The following is a description of a gene set: A circulatory system process carried out by the heart. The heart is a hollow, muscular organ, which, by contracting rhythmically, keeps up the circulation of the blood. The heart is a hollow, muscular organ, which, by contracting rhythmically, keeps up the circulation of the blood. Mouse Gene Set: GOBP_HEART_PROCESS species: Mus musculus, and this is the list of marker genes: Tac1, Kcnj5, Myl4, Pde5a, Drd2, Gjc1 (NCBI Gene Id 353069, gap junction protein, gamma 1), Zc3h12a, Sod1, Prkca, Sptbn4, Kcnj2, Fxyd1, Bin1, Flna, Sp4, Kcne5, Gch1, Tafazzin, Snta1, Rnls, Bves, Cxadr, Hbegf, Pebp1, Adora1, Trpm4, Map2k6, Oxt, Adrb2, Rgs4, Csrp3, Tmem161b, Chga, Znhit1, Scn4b, Ttn, Myh6, Tacr3, Rangrf, Hsp90aa1, Hey2 (NCBI Gene Id 30802), Adm, Irx3, Dsp, Ccn2, Cav1, Gaa, Actc1, Gata4, Myl7, Chrna7, P2rx4, Ucn, Pik3r1, Akap6, Pde4d, Adcy10, Smad7, Hopx, Ctnna3, Tmem38b, Fyn, Nedd4l, Kcnq1, Gja1, Kcnd3, Gpx1, Map2k3, Nmu, Adrb1, Avpr1a, Zfas1, Cacna1g, Hdac4, Smtn, Atp2a2, Edn2, Apela, Trex1, Cacna1h, Fgf13, Tnni3k, Slc8a1, Atp1b1, Kcne3, Kcna5, Kcnip1, Rap1gds1 (RAP1, GTP-GDP dissociation stimulator 1), Nkx2-5, Tnni3, Kcnh6, Gsk3a, Ext2, Atp5pf, Tbx18, Trpv1, Ada, Dmd, Stc1, Myl3, Tnni2, Mybpc3, Nos1, Ace, Zmpste24, Popdc2, Edn3, Pln, Nppa, Ramp3, Srebf1, Rps6ka2, Tnnc1, Slc1a1, Scn2b, Tcap, Adra1b, Chrm3, Myl2 (myosin, light polypeptide 2, regulatory, cardiac, slow), Rnf207, Myh7b, Dlg1, Rac1, Sumo1, Scn1b, Nup155 (nucleoporin 155), Rgs2, Slc4a3, Ednrb, Calm2, Mdm4, Gnai3 (G protein subunit alpha i3), Adm2, Ifng, Gnao1, Pik3ca, Hcn4, Gja5, Cdc42, Mdm2, Ptpn1, Camk2d, Kcnh2, Vegfb, Ace2, Cxcr4 (NCBI Gene Id 12767), Cacna1b, Kcnd2, Atg5, Tmem38a, Shox2, Scn5a, Nox4, Thra, Tgfb2, Isl1, Mef2a, Nos1ap, Myh7, Kcne2, Kcne4 (potassium voltage-gated channel, Isk-related subfamily, gene 4), Slc9a1, Pkp2, Casq2, Gsn, Kcnj8, Trdn, Tbx5, Cacnb2, Hrc, Sema3a, Atp1a3, Atp2a1, Chrm2, Crhr2, S100a1, Calm1, Scn10a, Dsg2 (NCBI Gene Id 52489), Ryr2, Tbx2, Smad5, Ppp1r13l, Agtr2, Tnf, Grk2, Strit1, Glrx3, Yap1, Edn1, Tnnt2, Myl1, Abcc9, Cacna1c (NCBI Gene Id 619317), Spx, Pmch, Uty, Klk1b1, Agrn, Dmpk, Irx5, Cacna1d, Cacna1e, Mtor, Ppcs, Ffar3, Tmem65, Akap9, Jup, Src, Gata6, 3425401B19Rik, Nos3, Kcnip2, Gpd1l, Srsf1, Wwtr1, Adra1d, Ext1, Gjd3, Sgcd, Adra1a, Ankrd11, Uts2, Dsc2, Npff, Sgcz, Sirt1, Scn3b, Psen2, Bmp10, Met, Thrb, Ank2, Kcne1, Mir208a, Glp1r, Th, Ednra, Atp2b4, Atp1a1, Tnni1, Epas1, Fkbp1b, Apln, Cacna2d1, Cav3, Kcnn2, Sgcg, Gnai2, Foxn4, Mc3r, Scn1a, Tpm1, Atp1a2, Calm3, Dnm1l, Agt, Ehd3 (NCBI Gene Id 57440), Sri